Given this list of marker genes SLC5A7, here is a description of the gene set: Reactome Pathway: Defective transport by SLC5A7 causes distal hereditary motor neuronopathy 7A (HMN7A) part of: SLC transporter disorders studied in species Homo sapiens The human SLC5A7 gene encodes a sodium- and chloride-dependent, high affinity choline transporter (CHT) transports choline (Cho) from the extracellular space into neuronal cells. Cho uptake is the rate-limiting step in acetylcholine synthesis, a neurotransmitter released at the neuromuscular junction (NMJ). Defects in SLC5A7 can cause distal hereditary motor neuronopathy 7A (HMN7A; MIM:158580). Distal hereditary motor neuronopathies are a group of neuromuscular disorders caused by selective degeneration of motor neurons in the anterior horn of the spinal cord, without sensory deficit in the posterior horn. The clinical picture consists of a progressive distal muscle wasting and weakness in the legs without clinical sensory loss.